Given this list of marker genes PREX1, ZNF124, LFNG (LFNG O-fucosylpeptide 3-beta-N-acetylglucosaminyltransferase), CLN3, DTNBP1, RGS3, ARMCX4, STK26, ASB2, MTMR12, CAPZB, KLHL6, SREBF1, TLE3, SYTL2, CD1D, ARHGDIB, TMX1, ZDHHC21, RAVER1, AJUBA (ajuba LIM protein), RNF145, SPTSSA, TCF12, CDK2AP2, AKR1C3, GOSR2, SERINC3, GEM, TM6SF1, MARCKS, SLCO3A1 (NCBI Gene Id 28232), MIEN1, MBOAT7, CFL1 (cofilin 1), ZAP70, LMO4, PTBP1, RAPGEF2, SLCO4A1, ACP3, RPS6KA3, E2F8, PTK2B, LCP2, HM13, THRAP3, IER5, RAP1B, CUL3, ACTR3B, NT5DC1, DOCK8, HSD3B7, TRAM1, LSM12, IFT27, EYA2, PPP2R1B, PLPP5, MYH9, CDCA4, KBTBD2, EPC1, ABHD16A, PSMB10, NOTCH1, TCF7, IRF1, CASP1, ABR, ABHD2, SGMS1, LANCL2, ATP8B2, HMGB2 (NCBI Gene Id 3148), DDC, BCL2L11, PSTPIP1, GCM2, AOPEP, UBALD1, NEDD9, ORAI2, EPAS1, COMMD7, ATXN7L3B, RNF26, SLC16A10, PAG1, ESYT2, DCP2, TMC6, ZBTB1, GLRX, NUCB1, C3orf38, FHL2, IL21R, RNF141, ADGRA3, CYFIP2, PFN1, PIP4K2A, RASAL3, MYLIP, DYRK2, TMEM229B, OXCT1, DNMT3B, FLNA, PRR14L, COL23A1, UBASH3A, HRC, CREB3, MFSD14B, CSGALNACT2, HVCN1, GLIPR1, PRPF18, MYD88, PDCD1, CPSF3, GPR155, RBM42, SEPTIN2, CALHM6, MAF, MLEC, CEP250, F2R, HCLS1, RASSF5, DNA2, RECK, SLC43A3, SLC28A2, ITGAL, PRXL2A, UNKL, MRPL52, TLN1, NECAP2, RAB27A, AQP9, CD52 (NCBI Gene Id 1043), GATA3, DUSP7, CROT, EBP, LAMTOR1, C9orf152, SEC16A, FBXO33, RPS6KA1, ACBD4, SLBP, TBK1, FNTB, CD82, LGALS8 (galectin 8), IL4, RCBTB2, TBC1D10C, MAP4K4, RBMS1, SGK1, CXCR3, RAB37, HIVEP3, OTULINL (NCBI Gene Id 54491), ELMO2, DAD1, DEPDC1, ID2, SEMA4A, DUSP2 (dual specificity phosphatase 2), MOB3A, TUBA4A, PGLYRP2, SELENOT, PDGFB, IL12RB1 (NCBI Gene Id 3594), ADCY7, RAB19, WDR44, USP20, ZNF14, ZNF764, SH3BP2, OLFM1 (NCBI Gene Id 22825), N4BP1, C1GALT1, STING1, GRAMD1B, TP53I11 (NCBI Gene Id 9537), MARCHF6, SETDB1, ERP29, here is a description of the gene set: Genes up-regulated in plasmacytoit dendritic cells (1h): untreated versus CpG oligodeoxynucleotide 1826. from publication Iparraguirre A, Tobias JW, Hensley SE, Masek KS, Cavanagh LL, Rendl M, Hunter CA, Ertl HC, von Andrian UH, Weninger W (PMID 18029397) CpG 1826 binds to Toll-like receptor (TLR)9, whereas influenza virus PR8 activates pDC via TLR7. Differential stimulation of pDCs is expected to result in unique activation mechanism(s) leading to a different phenotypically and functionally matured pDC We used microarrays to detail the global programme of gene expression underlying the maturation process of pDC activated with CpG 1826 and influenza virus PR8. We identified a distinct expression profile of upregulated immunomediators. studied in species Homo sapiens Human Gene Set: GSE7831_UNSTIM_VS_CPG_STIM_PDC_1H_UP